Given this list of marker genes Lgalsl, Kat8, Abhd14a, Apool, Fblim1, Ctdsp2, Tcim, Plekhf2, Grhpr, Crip1, Idh1, Flt3l, Cnot6l, Spin4, Bub1, Dusp6, Bhlhe40, Cast, Pkp2, Rcor3, Anp32a, Mfge8, Plac8, Stat1, Aox1, Sertad1, Cdk13, Nup98, Mndal, Fstl1, Tmtc4, Arhgap9, Rapgef3 (NCBI Gene Id 70104), Ndufb3, Egr1, Shox2, Tmcc3, Clu, Rnf217, Ctso, Akt3 (thymoma viral proto-oncogene 3), Vwa5a, Rfxank, Grcc10, Dmac2l, Morrbid, Grn, Spice1, Cep15, Gm15867, Abhd13, Klf9, Wfdc2, Mycbp2, Frk, Ppp1r35, Tapbp, Htatip2, Gbp2, Rnd3, Klf6, Zic5, Pla2g7, Ube2a, Mterf1b, Wdpcp, Naip2, Zc2hc1a, Ank1, Rab9, Myl6, Lrrc17, Hipk1, Dsel, Coasy, Steap2, Mettl4, Tmem263, Amot, Irak2 (NCBI Gene Id 74787), Hebp1, Mettl15, Glrp1, Arhgap12, Jun, Skap2, Ift25, Dbp, Zfp438, Sgo1, Tspyl1, Kmt2c, Hmgb2 (high mobility group box 2), Flot1, Ak3, Commd6, Artn, E2f7, Smim10l1, Cryzl1, Pura, Prkag2 (NCBI Gene Id 73700), Ttc13, Bnip3, Miip, 2510039O18Rik, Col5a2, Unc93b1, Gpr19, Decr1, Fam111a, Krt18, Immp2l, Ndufa13, Chml, Plekhf1, Krcc1, Far1, Mindy2, Arl3, Pias1, Pdk1 (NCBI Gene Id 78869), Pde5a, Cep57l1, Smad7, Col6a1, Rabgap1l, Ttc21b, Gm45351, Tm7sf2, Zbtb10, Smim29, Nsmce1, Hscb, Lrrc51, Sepsecs (Sep (O-phosphoserine) tRNA:Sec (selenocysteine) tRNA synthase), Rpl15, Rbpj, Mus81, Ube2t, Immp1l, Apip, Gbp2b, Gm42151, Sec62, Endou, Bnip3l, Srsf5, Amdhd2, Ptrh2, Hoxa1, Gjb5, Enpp1 (ectonucleotide pyrophosphatase/phosphodiesterase 1), Dynlt3, Hltf, Mutyh, Hpf1, Casp8, Snhg1, Chmp1b2, Mxd3, Errfi1, Dcbld1, Pim3, Lrr1, Higd1a, Sulf2, Tspo, Msln, Ldaf1, Ccn2, Zcchc13, Septin4, Rmdn1, Klf10, Thoc7 (NCBI Gene Id 66231), Pdia6, Casd1 (CAS1 domain containing 1), Tspan17, Kxd1, Wnt9a, Ccdc162, Hnrnpa3, Gadd45g, Rdm1, Spata6, Prkra, Rhobtb1, Cybrd1, Casp12, Plaat3, Marcks (myristoylated alanine rich protein kinase C substrate), Ackr3, Blvra, Snx14, Ripor3, Ssbp3 (single-stranded DNA binding protein 3), Cep41, Pdgfa, Pstpip1, Eef2k, Cep162, Chid1, Bcl2, 4930523C07Rik, Vapb, Ipp, Tor1aip2, Ifi203, Mzt1, Popdc3, H2-M3, Prelid2, Ak4, Wdr11, Klf3, Col6a3, Tent5a, Acat1, Cdc42ep3, Oaf (NCBI Gene Id 28152), Aadacl2fm1 (AADACL2 family member 1), S100a1, Hpcal1, Ccn1, Sgk2, Arid5b, Sos2, Hoxa5, 4933412E12Rik, Ndufaf3, Il12a, Adcy7, Nae1, Ppic, Cat, Sil1 (NCBI Gene Id 81500), Ccng2, Ubald2, Acss2, Tmsb4x, Pnkp, Zranb3, Wipi1, Dnajc3, Ankrd37, Trim12c, Spopl, Tsc22d3, Enpp3, Zfand6, Abhd8 (NCBI Gene Id 80593), Nol3, Nck2, Cryz, Cp, Fos, Nrarp, Tbc1d8b, Stx7, AA467197, Rbl1, Fbxl3, St6gal1, Pbxip1, Dipk1a, Zfand2b, Ubc, Cbr2, Pim1, Egln3, Plac1, Spidr, Uros, Tars3, Isg20, Clic1, Fem1c, Nit1, Nfkbiz, Vma21, Ormdl2, Mix23, Tmem238, Stim2, Bcl2l11, Lpin1, Pigbos1, Epb41l2, Atraid, Ncoa2, Lss (lanosterol synthase), Ogn, Ccdc90b, Pde6d, Rasa4, Ppp1r15a, Mospd2, Naxd, Fzd2, Leprot, Trim21 (tripartite motif-containing 21), Coq3, Apln, Glt8d1, Ermard, Pfkl, Ggh (gamma-glutamyl hydrolase), Gjb3, Rbm43, Ppp3cb, Rnf19a, Cldn9, Scrn1, Tmem37, Skil, Ebp, Stk17b, Sgk1, Xlr3a, Zfp729a, Phyhd1, Cdk10 (NCBI Gene Id 234854), H1f0, Prnp, Shld3, AI467606, Pdia4, 3110009E18Rik, Pltp, Slc66a3, Fbxo6, Zfp948, Clybl, S100a16, Pld1, Pcbd2 (pterin 4 alpha carbinolamine dehydratase/dimerization cofactor of hepatocyte nuclear factor 1 alpha (TCF1) 2), Sertad4, Pde7a (phosphodiesterase 7A), Ifi30, Cox20, Naip6 (NCBI Gene Id 272660), Cklf, Hacl1 (NCBI Gene Id 80601), Fgf15, Pnpla8, Ier2, Ugp2, Ndfip2, Id1, Loxl2, Rhob, Cox6a1, Ccdc38, Rras, Tmem205, Cep70, Tmem230, Cpt1a, Izumo4, 1600012H06Rik, Dennd5b, Acsl3, Ggta1, Snx24, Gsto2, Gmppa, 1600029O15Rik, Tgm2, Hexb, Ranbp6, Arhgap29, Trappc6a, Nr1d2, Gm2381, Tmco6, B230219D22Rik, Mgst3, Cnih2, Hikeshi, Itgb5, Cox7b2, Pcgf5, Plac9, Gstp3, Tjp1, Cln5, Idi1, Xbp1, Gsn, Hjurp, Cep72, Dnpep, Kansl1l, Morn2 (NCBI Gene Id 378462), Zdhhc2, Gcnt2, Cog4, here is a description of the gene set: Mouse Gene Set: MONNIER_POSTRADIATION_TUMOR_ESCAPE_DN Radiotherapy is widely used to treat human cancer. Patients locally recurring after radiotherapy, however, have increased risk of metastatic progression and poor prognosis. The clinical management of postradiation recurrences remains an unresolved issue. Tumors growing in preirradiated tissues have an increased fraction of hypoxic cells and are more metastatic, a condition known as tumor bed effect. The transcription factor hypoxia inducible factor (HIF)-1 promotes invasion and metastasis of hypoxic tumors, but its role in the tumor bed effect has not been reported. Here, we show that tumor cells derived from SCCVII and HCT116 tumors growing in a preirradiated bed, or selected in vitro through repeated cycles of severe hypoxia, retain invasive and metastatic capacities when returned to normoxia. HIF activity, although facilitating metastatic spreading of tumors growing in a preirradiated bed, is not essential. Through gene expression profiling and gain- and loss-of-function experiments, we identified the matricellular protein CYR61 and alphaVbeta5 integrin as proteins cooperating to mediate these effects. The anti-alphaV integrin monoclonal antibody 17E6 and the small molecular alphaVbeta3/alphaVbeta5 integrin inhibitor EMD121974 suppressed invasion and metastasis induced by CYR61 and attenuated metastasis of tumors growing within a preirradiated field. These results represent a conceptual advance to the understanding of the tumor bed effect and identify CYR61 and alphaVbeta5 integrin as proteins that cooperate to mediate metastasis. They also identify alphaV integrin inhibition as a potential therapeutic approach for preventing metastasis in patients at risk for postradiation recurrences. studied in species Mus musculus from publication Monnier Y, Farmer P, Bieler G, Imaizumi N, Sengstag T, Alghisi GC, Stehle JC, Ciarloni L, Andrejevic-Blant S, Moeckli R, Mirimanoff RO, Goodman SL, Delorenzi M, Rüegg C (PMID 18794119) The postradiation tumor escape signature: genes down-regulated in tumors from irradiated stroma vs those from non-irradiated stroma.